The following is a description of a gene set: Mouse Gene Set: CUI_LANGERHANS_IL36A_RESPONSE_DN from publication Cui A, Huang T, Li S, Ma A, Pérez JL, Sander C, Keskin DB, Wu CJ, Fraenkel E, Hacohen N (PMID 38057668) Genes negatively differentially expressed in cell type: Langerhans upon treatment with cytokine: IL-36α in mouse lymph nodes in vivo. studied in species Mus musculus Cytokines mediate cell-cell communication in the immune system and represent important therapeutic targets. A myriad of studies have highlighted their central role in immune function, yet we lack a global view of the cellular responses of each immune cell type to each cytokine. To address this gap, the authors created the Immune Dictionary, a compendium of single-cell transcriptomic profiles of more than 17 immune cell types in response to each of 86 cytokines (>1,400 cytokine-cell type combinations) in mouse lymph nodes in vivo. A cytokine-centric view of the dictionary revealed that most cytokines induce highly cell-type-specific responses. For example, the inflammatory cytokine interleukin-1β induces distinct gene programmes in almost every cell type. A cell-type-centric view of the dictionary identified more than 66 cytokine-driven cellular polarization states across immune cell types, including previously uncharacterized states such as an interleukin-18-induced polyfunctional natural killer cell state., and this is the list of marker genes: Hebp1 (heme binding protein 1), S100a4, Ucp2, Sat1, Rassf4, Icosl, Ostf1, Eno3